Given this list of marker genes GBA2, PGGHG, GBA1, GAA, SI, LCT, MGAM, MGAM2, GANAB, MOGS, KL, GBA3, GANC, AGL, here is a description of the gene set: Catalysis of the hydrolysis of glucosyl compounds, substances containing a group derived from a cyclic form of glucose or a glucose derivative. Human Gene Set: GOMF_GLUCOSIDASE_ACTIVITY species: Homo sapiens